The following is a description of a gene set: Genes up-regulated in CD4 T cells treated with IL1B and IL6 versus those also treated with TGFB1. CD4+ T cells that selectively produce interleukin (IL)-17, are critical for host defense and autoimmunity1-4. Crucial for T helper17 (Th17) cells in vivo5,6, IL-23 has been thought to be incapable of driving initial differentiation. Rather, IL-6 and transforming growth factor (TGF)-β1 have been argued to be the factors responsible for initiating specification7-10. Herein, we show that Th17 differentiation occurs in the absence of TGF-β signaling. Neither IL-6 nor IL-23 alone efficiently generated Th17 cells; however, these cytokines in combination with IL-1β effectively induced IL-17 production in naïve precursors, independently of TGF-β. Epigenetic modification of the Il17a/Il17f and Rorc promoters proceeded without TGF-β1, allowing the generation of cells that co-expressed Rorγt and T-bet. T-bet+Rorγt+ Th17 cells are generated in vivo during experimental allergic encephalomyelitis (EAE), and adoptively transferred Th17 cells generated with IL-23 in the absence of TGF-β1 were more pathogenic in this experimental disease. These data suggest a new model for Th17 differentiation. Consistent with genetic data linking the IL23R with autoimmunity, our findings re-emphasize the role of IL-23 and therefore have important implications for the development of new therapies. Human Gene Set: GSE23505_IL6_IL1_VS_IL6_IL1_TGFB_TREATED_CD4_TCELL_UP from publication Ghoreschi K, Laurence A, Yang XP, Tato CM, McGeachy MJ, Konkel JE, Ramos HL, Wei L, Davidson TS, Bouladoux N, Grainger JR, Chen Q, Kanno Y, Watford WT, Sun HW, Eberl G, Shevach EM, Belkaid Y, Cua DJ, Chen W, O'Shea JJ (PMID 20962846) species: Homo sapiens, and this is the list of marker genes: BRI3BP, PCDH12, SUPT7L, CFAP418, EEF2K, TRIR, PRXL2B, CIMIP4, LCLAT1, NBEAL1, DHX57, FAM118A, TMEM141, ATP6V0D1, GNG3 (G protein subunit gamma 3), MTLN, ADIPOR1, TRPM1, DRGX, TRPC5, SIPA1L1, AGL, ARSJ, FBXO6, TMEM131, DYNC2I2, SAA4, POU6F1, ZNF467, MRGPRE, LRRC14, ATOH7, PEX1, WDR43, ZFP36, JARID2, NEK4, MGAT5, CD22, WDR77, GNL2 (G protein nucleolar 2), STX6, TNS1, GPR183, QPCTL, MSL1, PTRH1, GSDMD (NCBI Gene Id 79792), IDUA, CEP68, RSU1, ZNF446, RASGRP4, DIABLO, PDE6D, CFAP157, PLCG1, ZNF710, PRDM5, MCEE, LIPA, MRPL52, INO80, ZNF516, HPN, CDK10, PECR, PIK3CD, KRTAP21-1, UTP18, SASH3, ORC4, UBA7, SIRT4, C8orf82, ALDOC, HMGN3 (high mobility group nucleosomal binding domain 3), RGP1 (NCBI Gene Id 9827), FBH1, EIF4G3, TSPAN13, SUCLG1, CDK5R1, IZUMO4, CD81, SHB, SETD4, MSI1, PLA2G5, NF1, ZNF444, GZF1, MIGA1, DNAJB5, CRX, AKAP8L, CRTC3, ZDHHC20, P3H1, BACE2, ZC3H12D, BCKDHB, GPI, POGZ, BAHD1, SLC16A5, SRSF11, NFKBIE, CRTAM, FASN, GCSH, SH3RF1, ASF1A (NCBI Gene Id 25842), HNRNPA1, OXSR1, FAM222B, STRA8, RPS10, DBP, SLC39A4, MYCBP2 (NCBI Gene Id 55685), ALKBH1, ZNF546, CST7, DMAC2, RARS2, TUBB2A, KLHL6, TMEM8B, FAM219B, ADAMTS6, CCDC126, PDRG1, IL4R, SLC26A11, DHX34, PRKDC (protein kinase, DNA-activated, catalytic subunit), CNOT2, FSD2, PHLDB1, ALKBH6, TNFRSF14, HEXA, DCAF11, SLC5A2, TMEM120B, SFMBT2, TOMM34, ANKRD12, RALGPS1, MED15, SSBP2, TBC1D32, SUGP1, ARRDC2, RNF167, RHBDF1, TGFBRAP1, KRT16, ZBTB20, NLK, SDHAF1, RASGRP1, PDZK1IP1, MAVS, MTERF3, TUSC2, OXCT1, TBC1D9B, S1PR2, HUWE1, MIA3, NT5DC1, GPT2, USP34, C3orf70, DAP3, KHDC3L, MRPL24, TNFSF8, LRRC71, C19orf33, MIA2, PFKM, SPNS1, NHLRC1, DECR1, RAB20, ISCA2, UBE2E1, CERS6, XRCC5, PIP5K1A, CKB, PLOD2, FYTTD1, SH3BP5, CABLES2, EARS2, MFHAS1